The following is a description of a gene set: Mouse Gene Set: GOMF_INTRACELLULARLY_GATED_CALCIUM_CHANNEL_ACTIVITY Enables the transmembrane transfer of a calcium ion by a channel that opens when a specific intracellular ligand has been bound by the channel complex or one of its constituent parts. studied in species Mus musculus, and this is the list of marker genes: Mcoln2 (NCBI Gene Id 99673), Mcoln1, Bnip1, Trpm2, Trpv1, Trpa1, Tpcn1, Itpr2, Ryr1, Rasa3, Pkd2, Itpr1, Itpr3, Mcoln3, Tpcn2, Ryr3, Ryr2